The following is a description of a gene set: Any process that stops, prevents, or reduces the frequency, rate or extent of neuron projection regeneration, the regrowth of neuronal processes such as axons or dendrites following their loss or damage. species: Homo sapiens Human Gene Set: GOBP_NEGATIVE_REGULATION_OF_NEURON_PROJECTION_REGENERATION, and this is the list of marker genes: FIGNL2, TNR, KREMEN1, EPHA4, KIAA0319, THY1, SPP1, RTN4R, RGMA, PTPRS, NEO1, CERS2, RTCA, RTN4RL1, INPP5F, LRIG2